The following is a description of a gene set: from publication Dudziak D, Kamphorst AO, Heidkamp GF, Buchholz VR, Trumpfheller C, Yamazaki S, Cheong C, Liu K, Lee HW, Park CG, Steinman RM, Nussenzweig MC (PMID 17204652) Genes up-regulated in splenic dendritic cells: DEC205+ versus B lymphocytes. Human Gene Set: GSE6259_DEC205_POS_DC_VS_BCELL_UP species: Homo sapiens Dendritic cells (DCs) process and present self and foreign antigens to induce tolerance or immunity. In vitro models suggest that induction of immunity is controlled by regulating the presentation of antigen, but little is known about how DCs control antigen presentation in vivo. To examine antigen processing and presentation in vivo we specifically targeted antigens to the two major subsets of DCs using chimeric monoclonal antibodies. Unlike CD8+ DCs that express the cell surface protein CD205, CD8- DCs, which are positive for the 33D1 antigen, are specialized for presentation on MHC class II. This difference in antigen processing is intrinsic to the DC subsets and associated with increased expression of proteins associated with MHC processing., and this is the list of marker genes: HPCAL1, AIF1L, SLC25A47, EPN2, CFC1, GPSM1, UNCX, GSTM2, HFE, CBLIF (cobalamin binding intrinsic factor), KRT75, TRIM75, MEGF6, GABRA3, AQP6, VGLL1, SCUBE1, TPH1, TICAM2, GPR3, FGFR3, UGT3A1, DRD2 (dopamine receptor D2), KRT12, COLEC10, HRH3, SOX14, POLR3K, GUCA2A, GARIN3, ACOX2, RS1, HIF3A, THSD4, EXT2, COLEC11, CACNA1G (NCBI Gene Id 8913), FGD5, AMIGO1, GUCY1A2, AIFM3, ADRA2A, SLC49A4, MIR338, SLC4A3, HMGA1, PPM1L, TBC1D10B, SLC7A14, MAP3K6, COQ9, BPIFB1, LY6G6D, SMAD6, ARRDC5, CDH4, PRG2, FTCD, FZD8, SNAPC5, GML, MYOZ3, TMEM74, TMEM212, EFNA2, OLFM1, CTSF, SPACA4, HOXA10, NAT14, MIR296, SLC26A9, EPPIN, CCDC74A, BCORL1, MXD3, MRGPRX1, KCNJ11 (potassium inwardly rectifying channel subfamily J member 11), NRBP2, HPN, BIK, MDFI, NKX2-6, MAPK8IP1, GLP2R, TGM1, SIX5, ABTB1, RAB33A (NCBI Gene Id 9363), BCO1, CCDC120, IL20, PLAC9, BBS1, STRC, SUPT20HL1, ITGAD, TCHH, ECEL1, STARD10, RTBDN, HS6ST3, CPN1, GPS1, FGF9, ATP6V0E2, DAO, SSBP3, NTM, DNAJC5G, DMRT1, UNC45B, ALG13, PPP3CC, DNAJC5B, FGFR4, GNG7, CACNB2, GGT6, REEP1, SHPK, ESX1, TNR, FBXO40, HECW2, CHRNA4, BEST3, TMEM200C (transmembrane protein 200C), TSPAN15, GPHB5, GMPR, CPLX3, ACSS1, DLGAP1, FOXB2, MEOX1, YPEL3, DIO3 (NCBI Gene Id 1735), IQCD, CRYGA, ABCA9, GCOM1, CBLN3, KRT35, KIFC3 (NCBI Gene Id 3801), CSPG4, DCBLD1, CES2, CD276, CHRNB1, GDAP1L1, KCNK1, CNKSR1, DMP1, TMPRSS4, GRIN1, NEK8